Given this list of marker genes AGT, BCL2A1, CAPN2, TNFRSF21, TNFRSF14, HTRA1, RELT, BOK, here is a description of the gene set: from publication Zeilstra J, Joosten SP, Dokter M, Verwiel E, Spaargaren M, Pals ST (PMID 18483247) Human Gene Set: ZEILSTRA_CD44_TARGETS_UP Mutation of the genes encoding the WNT signaling components adenomatous polyposis coli or beta-catenin plays a critical role in the initiation of colorectal cancer. These mutations cause constitutively active beta-catenin/TCF-mediated transcription, driving the transformation of intestinal crypts to colorectal cancer precursor lesions, called dysplastic aberrant crypt foci. CD44 is a prominent WNT signaling target in the intestine and is selectively expressed on the renewing epithelial cells lining the crypts. The expression of CD44 is dramatically increased in aberrant crypt foci in both humans and tumor-susceptible Apc(Min/+) mice, suggesting a role for CD44 in intestinal tumorigenesis. To study this role, we crossed C57BL/6J-Cd44(-/-) mice with C57BL/6J-Apc(Min/+) mice. Compared with C57BL/6J-Cd44(+/+)/Apc(Min/+) mice, C57BL/6J-Cd44(-/-)/Apc(Min/+) mice showed an almost 50% reduction in the number of intestinal adenomas. This reduction was primarily caused by a decrease in the formation of aberrant crypts, implying the involvement of CD44 in tumor initiation. The absence of CD44 in the normal (nonneoplastic) crypts of Cd44(-/-)/Apc(Min/+) mice did not alter the proliferative capacity and size of the intestinal stem cell and transit-amplifying compartments. However, compared with Cd44(+/+)/Apc(Min/+) mice, Cd44(-/-)/Apc(Min/+) showed an increase in the number of apoptotic epithelial cells at the base of the crypt which correlated with an increased expression of the proapoptotic genes Bok and Dr6. Our results show an important role for CD44 in intestinal tumorigenesis and suggest that CD44 does not affect proliferation but is involved in the control of the balance between survival and apoptosis in the intestinal crypt. species: Mus musculus Genes implicated in apoptosis that were up-regulated in duodenum of CD44 knockout mice.